The following is a description of a gene set: species: Homo sapiens Human Gene Set: GOBP_NECROPTOTIC_PROCESS A programmed necrotic cell death process which begins when a cell receives a signal (e.g. a ligand binding to a death receptor or to a Toll-like receptor), and proceeds through a series of biochemical events (signaling pathways), characterized by activation of receptor-interacting serine/threonine-protein kinase 1 and/or 3 (RIPK1/3, also called RIP1/3) and by critical dependence on mixed lineage kinase domain-like (MLKL), and which typically lead to common morphological features of necrotic cell death. The process ends when the cell has died. The process is divided into a signaling phase, and an execution phase, which is triggered by the former., and this is the list of marker genes: BOK, PARP1, CFLAR, RIPK3, MUTYH, FASLG, CYLD, MLKL, CAV1, ZBP1, IPMK, MIR107, AIFM1, RBCK1, MIR221, TNF, TRPM7, NLRP6, YBX3, TLR3, PGAM5, MIR214, OGT, PPIF, MIR103A1, TP53, FADD, ITPK1, MIR101-1, MIR22, MIR223, FAS, MIR485, RIPK1, ADPRS, PRKN, SPATA2, SLC25A4, FZD9, PYGL, CASP8, BIRC3, PELI1, ITCH, BIRC2, ARHGEF2, RNF31, CASP6